Given this list of marker genes Isoc1, Nabp1, Cdkn1a, Txnip, Pmm1, Ei24, Gvin-ps7, Ypel3, Cd53, Tob1, Dhrs3, Serpina3g, Trp53inp1, Vmp1, Adgre1, Ccng1, Btg2, Asnsd1, Lpin1, Malat1, Lilrb4a, Ablim1, Tmem185a, Mdm2, here is a description of the gene set: Genes up-regulated in FL5.12 cells (pro-B lymphocyte) in response to cisplatin. from publication Brachat A, Pierrat B, Xynos A, Brecht K, Simonen M, Brüngger A, Heim J (PMID 12447701) Mouse Gene Set: BRACHAT_RESPONSE_TO_CISPLATIN species: Mus musculus DNA microarrays are powerful tools for the analysis of gene expression on a genomic scale. The importance of individual regulatory events for the process under study can however not be deduced unequivocally without additional experiments. We devised a strategy to identify central regulators of cancer drug responses by combining the results of microarray experiments with efficient methods for phenotypic testing of candidate genes. We exposed murine FL5.12 pro-B cells to cisplatin, camptothecin, methotrexate or paclitaxel, respectively and analysed the patterns of gene expression with cDNA microarrays. Drug-specific regulatory events as well as intersections between different apoptotic pathways, including previously studied responses to staurosporine and interleukin-3 (IL-3) deprivation, were identified. Genes shared by at least three pathways were chosen for further analysis. Ectopic expression of three such genes, TEAP, GP49B, and Lipin1 was found to have an anti-proliferative effect on pro-B cells. Interestingly, we identified hemoglobin alpha as a strong pro-apoptotic regulator. While hemoglobin-expressing cells were growing normally in the presence of IL-3, they displayed accelerated apoptosis with similar kinetics as Bax overexpressing cells upon IL-3 removal. The pro-apoptotic effect of hemoglobin was suppressed by Bcl-2 and was characterized by enhanced stimulation of caspase activity.